The following is a description of a gene set: Co-inhibition by CTLA4 Mouse Gene Set: REACTOME_CO_INHIBITION_BY_CTLA4 species: Mus musculus, and this is the list of marker genes: Ppp2ca, Ppp2r5a, Ppp2r1b, Ppp2r5e, Akt2, Src, Ppp2r1a, Ctla4, Ppp2r5b, Yes1, Ppp2cb, Ppp2r5d, Akt1, Fyn (NCBI Gene Id 14360), Akt3, Ppp2r5c, Cd86, Lyn, Cd80, Lck, Ptpn11